The following is a description of a gene set: Cytokines mediate cell-cell communication in the immune system and represent important therapeutic targets. A myriad of studies have highlighted their central role in immune function, yet we lack a global view of the cellular responses of each immune cell type to each cytokine. To address this gap, the authors created the Immune Dictionary, a compendium of single-cell transcriptomic profiles of more than 17 immune cell types in response to each of 86 cytokines (>1,400 cytokine-cell type combinations) in mouse lymph nodes in vivo. A cytokine-centric view of the dictionary revealed that most cytokines induce highly cell-type-specific responses. For example, the inflammatory cytokine interleukin-1β induces distinct gene programmes in almost every cell type. A cell-type-centric view of the dictionary identified more than 66 cytokine-driven cellular polarization states across immune cell types, including previously uncharacterized states such as an interleukin-18-induced polyfunctional natural killer cell state. Mouse Gene Set: CUI_CDC2_IFNB_RESPONSE_UP from publication Cui A, Huang T, Li S, Ma A, Pérez JL, Sander C, Keskin DB, Wu CJ, Fraenkel E, Hacohen N (PMID 38057668) Genes positively differentially expressed in cell type: cDC2 (conventional dendritic cell type 2) upon treatment with cytokine: IFN-β in mouse lymph nodes in vivo. studied in species Mus musculus, and this is the list of marker genes: Selenow, Uba7, Gnb4, Pgap2, Bcl9, Scimp, Traf1 (NCBI Gene Id 22029), Cebpb, Rars1 (NCBI Gene Id 76827), Bst2, Mxd1, Treml2, Dcp2, Scamp2, Spi1, Hspa5, Atp6v1d, Znfx1, Igtp, Nr1h3, Ccl2, Hmgn3, Stxbp3, Ankle2, Azi2, Tbc1d8, Socs1, Jaml, Hk3, Dpy19l1, Tent2, Ly6i, Cd274, Abcb1a, Notch1, Rab8b, Marcksl1, Sgcb, Ascc3, Phlpp1, Ifit1, Cmpk2, Rbms1, Pml, Chmp4b, Slfn2, Cdkn2d (NCBI Gene Id 12581), Serinc3, Naa25, Gatm, Trim30a, Rbm43, Wdr86, Fbxw17, Dnajb11, G3bp2, Trim30d, Slc25a22, Svbp, Pstpip1, Actr2, Rasa4, Akr1a1, Ikzf2, Mier3, Ifih1, Suds3, Ccnd2, Nsd3, Clic4, Cxcl9, Gsdmd, Dennd1a, Dtx3l, Capza2, Parp14, Adar, Gbp3, Cpne3, Il3ra, Snx10, Slfn8, Zc3hav1, Ifi213, Mthfd2, AA467197, Rala, Phf11d, Oasl1, Mndal, Cd47, Ikzf1, Nlrc5, Ncoa1, Xaf1, Usp12, Stard3, Apool, Isg15, Clec2d, Slfn1, Rtp4 (receptor transporter protein 4), Adap1 (NCBI Gene Id 231821), Irf5, Sct, Fbrsl1, E2f2, Rnf114, Epsti1, Bcl2a1b, Nfkbib, Adap2, Plaat3, Camk2d, Daxx, Casp1, Sdc3, Tap2, Bcl2a1a, Bbx, Irgm1, Calm1, Themis2, Dop1b, Lrp8, Itpr1, Acp2, Gmppb, Nes, Axl, Rrad, Ankib1, Sp100, Acadl, Trim56, Ttc7, Anxa1, Ctss, H2-T23, Cct3, Cycs, Trim34a, Stat1, Trim30c, Il15, Tor1aip2, Snx2, Cd2, Lamp2, Sass6 (NCBI Gene Id 72776), Clec9a, Fcgr1, Isg20, Morc3, Fbxo11, Pdcd10, Dync1h1, Ppp1r11, Crybg1, Tpst1, Hk1, Runx3, Abi3, Lipg (NCBI Gene Id 73116), Apobec3, Ranbp2, Nono, Lrch1, Psmb8, Atp1b3, Bcl2a1d, Usp25, Ywhah, Eif2ak2, Tbl1x, Tgm2, Id2, Ogfrl1, Ifit3b, Gadd45b, Rnf34, Ppp1r2, Zyx, Slc29a3, Dhx58, Rnpep, Nqo2, Rigi, H2-T24, Nfkbie, Trim12a, Grb2, BC031181, Prpf38a, Stx16, Ddx24, Endod1, Washc4, Arf6, Tcof1, Il2rg, Tmem106a, Serpina3g, Mpeg1, Aff1, Lgals9, Sap30, Tspan13, Mitd1 (MIT, microtubule interacting and transport, domain containing 1), Lpxn, Nampt, Socs2, Tbc1d32, Rnh1, Atp8a1, Cd86, Cflar, Stx11, Stat2, Qpct, Jpt1, Dnajc7, Fcer1g, Tmbim6, Lrch3, Spred1, Aig1, Trim14, Npepps, Ywhae, Gch1, Tmem219, Ifit1bl1, Herc6, Ifi207, Slc30a1, Tpm3, Pnp, Usp18, Taf15, Mov10, Cap1, Aftph (NCBI Gene Id 75762), Glrx, Fnbp4, B4galt4, Cd52, Zc3h7a, Ift172, Lgals3bp, Kpna3, B2m, Tmem184b, Carmil1, Macir, Sumo1, Hsp90aa1, Dck, Tor3a, Dnaja1, Rap1b, Dnajb6, Sh3bp2 (SH3-domain binding protein 2), Trp53i11, Oas1g, Aplnr (apelin receptor), Rap2c, Mrpl39, Myd88, Keap1, Slc15a3, Oasl2, Ppp6c, Usp15, Ifi44, Ctsz, AI837181, Dok1, Marchf5, Xdh, Cacybp, Rmdn3, Irf7, Phf11a, Ccdc102a, Ostf1, Tnfsf10, Fndc3a, Pfkp, Pcsk7, Ly6a, Il15ra, Il18, Slfn9, Ptms, Tspo, Tarm1, Tpm4, Etnk1, Creb5, Sh2b3, Sema4d, Bcl3, Cd300lf, Cgas, Hck, Cdkn1a, Slfn3, Tapbpl, Trim30b, Tmem131 (NCBI Gene Id 80568), Icam1, Ubc, Nras, Bri3, Pnp2, Dek, Ppp1r14a, Gbp8, Slc7a8 (NCBI Gene Id 50934), Flnb, Grn, Pdk3, Dusp2, Tcstv4, Dbnl, Aldh1b1, Tfg, Slc36a3os, Gca, Hnrnph2, Hmox2, Ankrd17, Ifi203 (interferon activated gene 203), Sat1, Ptpn6, Phf11c, Timeless, Sp110, Dnajc13, Arid5a, Casp8, Oas2, Isoc1, Ppa1, Ankfy1, Ifi205, Rufy3, Tpx2, Rhoh, Anxa4, Sdcbp, Csrnp1 (cysteine-serine-rich nuclear protein 1), Triobp, Khdrbs1, Amn1, Zfp800, Ube2l6, Plaur, H2-T22, Larp1, Srsf7, Ccr7, Trafd1 (TRAF type zinc finger domain containing 1), Plekho2, Slco3a1, Cyrib, Abcg1, Ifi208, Tomm70a, Frmd4a, Bex6, Wdr43, Map2k1, Cldnd1, Rin2, Nectin4, Tapbp, Oas1a, Atp6v1b2, Sar1a, Mlkl (mixed lineage kinase domain-like), Psmb9, Mthfr, Srsf3, Tagln2, Rhbdf2, Tdrd7, Etv6, Ube2e1, Arl6ip1, Hspa8, Itm2b, Ly86, Mcmbp, Ms4a6c, Prdx1, Zup1, P4ha1, Csrp1, Slirp, Ilrun, Calhm6, Shisa5, Fgl2, Hspe1, Il10ra, Cfb, Slc7a11, Fn1, Ncf1, Adap2os, Hap1, Sfr1, Cxcl10, Asb13, Arf4, Plac8, Eloa (elongin A), Anxa5, Gbp7, Snrnp27, Ifit3, Rilpl1, Slamf9, Ube2d3, Ccl5, Glipr2, Atp6v0a2, Sh3glb1, Ubr4, Ythdf1, Sppl2a, Lrrfip1, Dnajb1, Iigp1, Atp10a, Ifi209, Oas3, Coro2a, Cyth4 (cytohesin 4), Mllt3, Mpp1, Ift22, Nod1, Tbc1d1, Klrk1, Gbp2 (guanylate binding protein 2), Dnase1l3, Nrp1, Il21r, Mx1, Hdc, Tent4a, Tnfrsf1a, Ddx4, Ifi204, Cnn3, Rab10, Tmpo (thymopoietin), 9930111J21Rik2, Ifi35, Pnpt1, Parp12, Gbp5, Cd164, Tmem229b, H2-D1, Hsp90ab1 (NCBI Gene Id 98078), Parp11, Trim12c, Nrros, Spop, Nmi, Ms4a6b, Fxr1, Tmem51, Casp4, Actr3 (NCBI Gene Id 74117), Selplg (NCBI Gene Id 20345), Cited2, Peli1, Sash1 (SAM and SH3 domain containing 1), Dennd1b, Plekhf2, Irf8 (NCBI Gene Id 15900), H3f3b, Actg1, Zbp1, Mfsd12, Rpf2, Cd69, Tbrg1, Edem1, Naa20, Pttg1, Vps37b, Actr10, Vdac3, Gbp4, Phyh, Cd72, Il18bp, H2-K1, Mvp, Fcgr4, Cnp, Slamf8, Rab5c, Samd9l, Ncoa7, Ptk2b, Ccnd1, P2ry14, Mat2a, Lgals8, Parp10, Dusp5, Adck1, Tex9, Ly6e (NCBI Gene Id 17069), Helz2 (helicase with zinc finger 2, transcriptional coactivator), Stat3, Ubb, Chmp5, Serpina3f, Tor1aip1, Txn1, Phip, Npc2, Fam241a, Ccdc86, Ms4a6d, Acer3, Tap1, Trim25, Gramd2b, Pcgf5, Stard5, Stk39, Irgm2, Ankrd12, Evl, Slfn5, Psma5, Armcx6, Sell, Dnaja2, Tmsb10, Hif1a, Ddx60, Unc93b1, Atp13a1, Gpbp1, Bak1, Rell1, Hat1, Tagap, Prkx, Rnf115, Ifi206, Casp3, Samhd1, Vwa5a, Ms4a4b, Cd40, Hdac1, Ms4a4c, Slc25a12, Aida, Ifi27l2a, Ifit2, Plin2, Parp9, Psma3 (NCBI Gene Id 19167), Slc7a7, Rsad2 (radical S-adenosyl methionine domain containing 2), Rfc3, Tle3, Anxa7, Irf1, Max, Trip12, Nt5c3, Mbd2, Psme2, Tgtp1, Ass1, Il27, Mafk, Usb1, Pkib, Ifi47, Ifitm3, Selenot, Psmb7, Phc2, Pdia3, Asb2, Psme1, Vcpip1, Phf11b, Psma4, Gpr141, Hspa1b, Il1rn, Sp140, Cdc42se1, Rab1a, Sfxn2, Serpinb9, Psmb10, Kdr, Ogfr, Ifi211, Rnf213 (NCBI Gene Id 672511), Cyba, Ifi214, Tcirg1, Gbp9, Fyn, Setdb2